Given this list of marker genes IRS1, WDR45, ESRP1, VPS13B, RIPOR2, TLCD5, TMPRSS2, CCDC28B, ITGB4, H1-2, DTX3L, CES2, BMF, FUOM, COL6A4P1, HDAC5, ZNF521, TNNT1, EXTL3, ABHD4, RASD1, CTSB, MSX1, LARP6, APOD, UGT1A10, MUC1, CELF2, FGL2, TMEM176B, QPCT, BCHE, HVCN1, P2RX7, GLMP, ANK3, RND2, FLOT1, PHACTR2, GUCY1A1, REPS2, TRPM4, SFT2D2, ABHD14B (NCBI Gene Id 84836), PLAT, UNC93B1, DDRGK1, VLDLR, SDC4, CTSF, TP53INP1, VWF (von Willebrand factor), CREG1, SLC48A1, MYCN, LCN2, ITPR2, KCNJ8, PRXL2C, MKRN1, SLCO2B1, CLDN3, LRPAP1, RBM24, NTRK2, USE1, SMARCA1, ENTPD1, CD82, NATD1, CA2, TBC1D4, LYZ, UBA7, C14orf132, NAGA, TMEM132C, SERPINA1, PIK3R3, SERINC2, DAP, MMP11, PRKAR1B, H1-0, TRPS1, NGFR, DGKA, AARD, RAB31, IRF6, SLC2A8, SNORD65, AGO1, CTXN1, ANXA6, APPL2, SPOCK2, DAZAP2, WLS, RSPH3, HLA-B, KCNG1, IER3, CNP, CPLX2, PTH1R, BLVRB, FBLIM1, FZD6, CPXM1, TMT1A, SLC24A3, BCL2, TNFSF12, GSTT2, OASL2P, PLSCR1, TMEM45B, ERN1, NNAT (neuronatin), FYCO1 (FYVE and coiled-coil domain autophagy adaptor 1), CYP27A1, FNDC5, CCDC136, ACSL4, CHKB, BEX1, SCRN1, RESF1, CTDSP2, IFI44L, LAMA2, DAPK1, TNFSF13, ATP2B2, LIPE, CHDH, RAB6B, NIPAL3, TMEM86A, ITGB5, TRPV6, ENTREP1, MAL2, RUSC1, GBP4, AFAP1L2, CPE, SLC6A9, RBM39, OTUB2 (OTU deubiquitinase, ubiquitin aldehyde binding 2), PELI2, EZR, GABRP, PNMA8B, PTPRD, SSC5D, C1R, TJP2, SAMD14, GPR146, SCARB2, CIRBP, CYP2D6, FBLN5, JAM2, HAGHL, MPZL2, DDIT4L, ARL4C (ADP ribosylation factor like GTPase 4C), GHR, SLC15A2, LIPG, TAP2, SORCS2, RAMP1, CRYZL2P, OSR2, ANTKMT, TIMP2, CAST, JAK2, RHOBTB1, TSC22D1, C1S (NCBI Gene Id 716), APOE, BTG1, ATOSA, HOXB6, INAVA, SMARCA2, CD59, GRB7, TCF21, RPL22, SULT1D1P, CCL11, DLX5 (NCBI Gene Id 80275), IRAG1, CAPN5 (calpain 5), KRT15, BMP7, EDNRA, ASPG, COL18A1, RGMA, RNASE4, C11orf54, RADIL, C12orf57, NAPRT, PRSS8, LMO2, PRLR, P2RY14, STARD9, TSPAN8, CDH1, PTPRR, WFS1, DNAJC28, TFCP2L1, EMB, DIO2, ADRA2A, GGT5, PAMR1, SFTPD, KDF1, JUN, TMEM30B, VTN, KRT88P, AOC3, ALDH1A2, LRP10, LEPR (NCBI Gene Id 3953), FNBP1, SATB1, BMP1, NTN4, MAP1LC3B, CYP4V2, ZFAND3, DTX4, ENPP2, CALCOCO1, RAB20, PXYLP1, H6PD (hexose-6-phosphate dehydrogenase/glucose 1-dehydrogenase), HIGD1B (HIG1 hypoxia inducible domain family member 1B), SPSB4, LTF, ARHGEF26, IFITM1, RAI2, GLB1, THRA, RSPO3, SLC7A7, GPX2, FZD7, GRN, ABCA1, PHF11, EVA1B, NAAA, FUCA1 (NCBI Gene Id 2517), ARF5, LDHB, F3, ILVBL, SETD7, SERPING1, KIF16B, F5, RNF128, AEBP1, PADI1, RGL3, CASP1, CBX6, RAB25, PNRC1, TMCC3, MXD4, FAM20A, CXCL17, MINDY4, DDB2, GALNT15, AOX1, MAB21L3, CYB5R3, TMPRSS4, STOM, CNPPD1, FBXO32 (NCBI Gene Id 114907), NFIA, TMEM200C, PTPRB, VAT1, PDPN, MAF1, CKMT1B, EHF, SLC39A8 (solute carrier family 39 member 8), CSAD, MME, MANBA, CUL7, KCNAB1, MECOM, SCN7A, PBXIP1, PLOD1, REN, RARRES2, FIRRE, CLN3, IL18, IGSF3, ZNF395, RAB13, CDH13, WFDC2, MAMDC2, PRELP, CTSH, PLD1 (NCBI Gene Id 5337), SLC5A8, ADCY4, SLC25A23, MAN1A1, ABCB1, FAM124A, KCNK1, TEK, GAA, ACAD8, PDZK1IP1, MCEE, ADGRG6, ITM2A, HEXA, COL6A1, P2RX4, ITGB8, AXIN2, PHLDB1, RTKN, SASH1, CCDC80, SNCAIP, TRAF5, KRT19, TAPBP, MTURN, RERE, RTN2, CYFIP2, OXLD1, KLHL32, S100A1, RIMS1 (NCBI Gene Id 22999), LRRK1, CTSO, H1-10, SH3BGR, RAMP3, MSC, C19orf33, CP, ARNT2, KRT18, CXCL12, BCKDHA, EMP2, SLC35G1, KLHL24, YPEL3, CRY2, CLEC14A, HDC, H2AZ2, SGPP2, SLC10A6, FGD4, RFXANK, CLIP3, ZNF124, OLFML2A, MAF, CEBPD, CRIP1, EFS, IRGM, PDK2, CPQ, PLTP, TMEM176A, ALCAM, DDR1, TCTN1, CHD3, CKB, ANGPTL2, NKD2, PROM1, CREBRF, LRRC17, TXNIP, TMTC2, HTRA1, FCGRT, NPNT, NREP, PPM1E, PCP4, GCNT1, ANPEP, VAV3, SPON1, CHODL, PIK3IP1 (phosphoinositide-3-kinase interacting protein 1), GNG2, AMPD3, HACD4, DMPK, CLSTN1, RNF130, NRTN, KLF9, NFE2L3, LPL, GREB1, FAAP20, SNORD12C, RCSD1, RENBP, TIE1 (NCBI Gene Id 7075), PAM, UAP1L1, PER3, MFAP2, CTSD, SCARB1, TCP11L2, SULT1A1, CGNL1, FLCN, MSRB1, ALDH6A1, RASD2, APOBEC3B, BCL2L11, CPZ, AQP8, CD14, FAM20C, HK1, DCXR, KCND2, FUT9, TAMALIN, DEGS2, TEF (NCBI Gene Id 85370), COLEC11, PPP1R14B, ALOX15, PADI4, PTGER3, JMY, LRP1, NDRG2, NBL1, IFIH1, PPP1R9A, INAFM1, TNXB, SGMS2, LTBP1, SESN1, RAD51B, PIGP, RBPMS (RNA binding protein, mRNA processing factor), VSIR, MMRN2, KCTD1, SNRK, CASP12, PCK2, MFGE8, GDPD1, DPP4, COL7A1, CCDC198, CLDN23 (NCBI Gene Id 137075), HTRA3, COL6A2, GBP2, PARD3B (NCBI Gene Id 65063), CALML4, PDCD4, COL5A1, SFRP4, QPRT, PLEKHS1, PLPP2, GSTT1, CPXM2 (carboxypeptidase X, M14 family member 2), PLEK, MEIS2, ATP1B2, AKR1B10, RGS3, EGFLAM, YPEL2, THBS3, MGP, DSP, ITM2B, GRB14, NAA80, ETFBKMT, GLB1L2, DDAH2, GDA, PLSCR4, NAGLU, IGF2R, METTL26, AK3, PPP1R12B, GSTO1, HDAC11, ZNF608, ARMC10, CILP, ADH1A, TCN2, BPHL, CALB1, MATN2, CRISPLD1, NPR2, PLPP6, TTC28, SNX21, IP6K2, CNDP2, SLC31A2, PYGB, CLDN34, PRXL2A, RRAS, MMP23B, HPGD, KCTD14, KRT8, PLET1 (placenta expressed transcript 1), ENPP3, SH3YL1 (NCBI Gene Id 26751), SESN3, CORO1A, FRMD4B, DDIT4, FOXO1, IP6K1 (inositol hexakisphosphate kinase 1), INHBB, SELENOM, PLAAT3, IL17RD, CRYL1, SMIM29, DCHS1, CRISPLD2, SPINT2, SV2B, PIGR, PDLIM2, TGFB1I1, FOXL2, KRT7, PKN1, ATP1A2, CRYZ, CSRNP3 (cysteine and serine rich nuclear protein 3), AMHR2, ASB2, HYI, PGM5, FBXL20, FMO2, ATP1B1, MAPKAPK3, SLC7A2, KDM7A, RNASEL, NMI, NCALD, MXRA8, EBP, MAP1LC3A, SLC26A7, ATP8A1 (NCBI Gene Id 10396), ARHGAP6, SMAD1, HSPA12B, FOXO3, STXBP6, ITM2C, CREB5, PDXK, AHNAK2, BACE2, CA12, TMC4 (NCBI Gene Id 147798), SUN2, SCMH1, AQP1, LRIG1, MAL, GABARAPL1, MSRB3, AOX3P, NOTCH3, KIAA0040, AR, TMEM140, WIPI1, RAB29, USP18, REV3L, AAMDC, CHCHD10, SEMA4A, PLXNB2, APOBEC1, PLIN3, DHRS7, CLDN7, BSPRY, SYNPO2, CLU, ITGB3, RRAGD, SMPDL3A, IFT46, ADHFE1, ADCY6, SAT1, PPP1R14A, COQ8A, FXYD1, RECK, ST14, OPLAH, EPHX1, PINK1, OXTR, EPS8, ZFYVE26, HBP1, SLC17A5, FXYD6, TMEM35B, NENF, GRINA, PRSS23, LTBP4, IRF2, PGGHG, PDK4, CTSA, TBC1D17, PSRC1, AGRN, PNPLA7, CDC37L1, PRKD3, EFEMP1, NUPR1, SLC40A1, GSTM5, TSPAN1, MFAP4, SELENOW, AGTR1, NR1D2, SLC39A4, IGFBP5, STMND1, KANK2, SERINC3, PDGFA, ANGPTL7, THBD, RNF167, TCIM, INPP4B, FADS2B, PCBD1, DCAF8, SNAI2 (snail family transcriptional repressor 2), NEAT1, PIK3R1, RFTN2, DPT, ACACB, ADAMTSL1, ELAPOR1, PTK2B, OCIAD2 (NCBI Gene Id 132299), ACAA1, NPDC1, IGFBP6, GSDMD, CYP39A1, SLC16A2, URAHP (NCBI Gene Id 100130015), ZBTB16, CLDN10, CLCA1, FAM107A, ZNF467 (NCBI Gene Id 168544), NUMA1, HSD17B11, MSRB2, CCNG2, TRIM45, C16orf89, DBP, TMEM213, ABCA9, ZFP36L1, MLPH, ASCC1, SPP1 (NCBI Gene Id 6696), CITED4, LAD1 (NCBI Gene Id 3898), PDE5A, TRIL, RAB7B, JAG1 (jagged canonical Notch ligand 1), EPCAM, METTL27, NUDT7, GPM6B, ZBTB4, C1GALT1, SEPTIN4, COL4A4, EFHD2, TMEM26, DSG2, SERPINB1, PAOX, FOXP1, VWA5A (NCBI Gene Id 4013), H2AC25 (NCBI Gene Id 92815), DPYD, BCAT1, PSMB8, RABGAP1L, DEPTOR, EEIG2, LIX1L, CACNB3 (NCBI Gene Id 784), MYLIP, PYCARD, RNF150, PHPT1, here is a description of the gene set: from publication Lee KY, Jeong JW, Wang J, Ma L, Martin JF, Tsai SY, Lydon JP, DeMayo FJ (PMID 17515606) Human Gene Set: LEE_BMP2_TARGETS_UP species: Mus musculus Genes up-regulated in uterus upon knockout of BMP2. The process of implantation, necessary for all viviparous birth, consists of tightly regulated events, including apposition of the blastocyst, attachment to the uterine lumen, and differentiation of the uterine stroma. In rodents and primates the uterine stroma undergoes a process called decidualization. Decidualization, the process by which the uterine endometrial stroma proliferates and differentiates into large epithelioid decidual cells, is critical to the establishment of fetal-maternal communication and the progression of implantation. The role of bone morphogenetic protein 2 (Bmp2) in regulating the transformation of the uterine stroma during embryo implantation in the mouse was investigated by the conditional ablation of Bmp2 in the uterus using the (PR-cre) mouse. Bmp2 gene ablation was confirmed by real-time PCR analysis in the PR-cre; Bmp2fl/fl (termed Bmp2d/d) uterus. While littermate controls average 0.9 litter of 6.2+/-0.7 pups per month, Bmp2d/d females are completely infertile. Analysis of the infertility indicates that whereas embryo attachment is normal in the Bmp2d/d as in control mice, the uterine stroma is incapable of undergoing the decidual reaction to support further embryonic development. Recombinant human BMP2 can partially rescue the decidual response, suggesting that the observed phenotypes are not due to a developmental consequence of Bmp2 ablation. Microarray analysis demonstrates that ablation of Bmp2 leads to specific gene changes, including disruption of the Wnt signaling pathway, Progesterone receptor (PR) signaling, and the induction of prostaglandin synthase 2 (Ptgs2). Taken together, these data demonstrate that Bmp2 is a critical regulator of gene expression and function in the murine uterus.